The following is a description of a gene set: Mouse Gene Set: GOMF_NOTCH_BINDING Binding to a Notch (N) protein, a surface receptor. species: Mus musculus, and this is the list of marker genes: Dner, Kctd10, Jag1, Adam17, Sned1, Dll1, Ccn3, Tcim (transcriptional and immune response regulator), Snw1, Notch1, Cul3, Megf10 (NCBI Gene Id 70417), Hif1an, Dlk2, Dtx1, Atrnl1, Aak1, Notch4, Egfl7, Jag2, Dll4, Chac1, Dll3, Ncor2, Galnt11